Given this list of marker genes SNX19, IZUMO3, CHN2, AQP1, TMPRSS12, ACTL7A, NECTIN2, SPINK2, GARIN1A, F2RL3 (NCBI Gene Id 9002), AP1B1 (NCBI Gene Id 162), CREB1, RAB38, CYLC1, LYST, HPS3, MFSD14A, AGFG1, ZNF385A, BLOC1S1, PLN, ABCA1, AP3S1, AP1S2, RFX2, TMF1, DTNBP1, PFN4, POC1B, BLOC1S3, VPS33B, ZPBP2, ZPBP, AP3S2, AP3B1, GARIN3 (NCBI Gene Id 153745), KNL1, SLC35D3, AP3M1, AP1S1, SPACA1 (NCBI Gene Id 81833), BAIAP3, PDCL2, HID1, AP1G1, SERPINE2, AGFG2, CCDC136, PTPRN, HPS6, HPS1, SPPL2C, F2R, CCDC38, SOX30, TBC1D20, DCAF17, CCDC42, KCNE1, SRGN, ACRBP, AP1S3, OSBP, TBPL1, VPS13B, PLA2G3, AP1M1, HPS5, PAFAH1B1, ACTL9, KIAA0319L, GARIN1B, SLC9A8, BLOC1S2, HPS4, AP3D1, here is a description of the gene set: Human Gene Set: GOBP_SECRETORY_GRANULE_ORGANIZATION species: Homo sapiens A process that is carried out at the cellular level which results in the assembly, arrangement of constituent parts, or disassembly of a secretory granule. A secretory granule is a small subcellular vesicle, surrounded by a membrane, that is formed from the Golgi apparatus and contains a highly concentrated protein destined for secretion.